The following is a description of a gene set: studied in species Homo sapiens Any process that results in a change in state or activity of a cell or an organism (in terms of movement, secretion, enzyme production, gene expression, etc.) as a result of a nitric oxide stimulus. Human Gene Set: GOBP_RESPONSE_TO_NITRIC_OXIDE, and this is the list of marker genes: HNRNPD, ATP5F1A, GATA5, PTPN1, CCR7 (C-C motif chemokine receptor 7), MTR, CCL19, CRK, AQP1, KCNC2 (NCBI Gene Id 3747), EGLN1, TRAF2, SCN11A, CFLAR (NCBI Gene Id 8837), TXN, GUCY1B1, CDK2, CCNA2, MMP3, AIFM1 (apoptosis inducing factor mitochondria associated 1), FOXO1, DPEP1